Given this list of marker genes ARL4A, MAPK1, TALDO1 (NCBI Gene Id 6888), MED21, FLOT1, COX7A2, MAD2L1BP, NBN, FES, FCER1A, GTF2H5, NAGK, ACSL1, RENBP, CSRNP2, RAI14, ALDOA (NCBI Gene Id 226), RAB31 (RAB31, member RAS oncogene family), HSP90AB1, PROCR, BST1, ABCA3, TUBA1C, SLC27A2, NDUFS6, NTRK1, MS4A6A, MKLN1, PTAFR, TRAPPC4, DAPK2, PMEPA1, QPRT, MARCHF2, BASP1, MEIS2, RHOQ, CCL23, ETNK1 (ethanolamine kinase 1), CYFIP1, RREB1, STK3, NUDT1, PSMC6, DOCK6, DDX41, ETV5, MFAP1, HSD17B4, PINLYP, ENPP2, PAPSS1, IDI1, ZFP69B, EXTL2, MTHFD1, DCTN6 (NCBI Gene Id 10671), MRPL15, IGF2BP3, IL1RN, PLTP, CHST11, TMEM70, PPIP5K2, HS3ST1, CRNKL1, YBX3, LYL1, COPB2, CAVIN2, KLHL2, COA3, PCOLCE, AGPAT4, GPI, EIF4A1, CMA1, TSC22D1, ADGRA3, ENPP4, CHN2, CDC42BPA, COX8A, CHFR, CCT5, VDAC1, WIPI1, DUSP6, DRAM1, NDUFB4, USP48, NQO2, FCER1G, SEL1L, FCGR2C, TMEM53, ACY1, CSF2RB, DST, CERS2, PLXND1, POLR2L, CHST15, TKT, SOX4, LPXN, MSRB2, ARHGEF6, CSNK2B, LYN, NDUFA4, USP22, ZNF804A, EOGT, MT1M, GALC (galactosylceramidase), LYST, ERP44, C1orf216, SQSTM1, MYO1D, ENTREP3, PICALM, UQCRFS1, CHKA, SLC48A1, BLVRA, NPL, ZNHIT1, RASSF2, APMAP, COBLL1, FECH, ATP6V0D1 (ATPase H+ transporting V0 subunit d1), CEBPG, TMSB15B, HEATR6, NDRG2, GSTT1, TCN2, ATP2A2, APC, C5AR1, TIMM8B, TBK1, SOCS5, NME1, GPD1L, COMMD4, FOSL1, ENSA, KCNH2, CKS2, IFNGR1, TXNRD1, PDSS1, ITGAX, PLA2G15, TNPO3, WARS2, SLC30A1, MAFG (MAF bZIP transcription factor G), SPP1, PPM1H, CENPU, WBP4, M6PR, AP4S1, HEXA, MTCH2, GNS, ALDH1A1, WDR12, ILF2, TUBB3, ENY2 (NCBI Gene Id 56943), GSN, NOP16, TPSG1, ACSL4, TMT1A (thiol methyltransferase 1A), SMYD3, CORO1C, TRHDE, TST, PIR, XPNPEP1, HMGCS1, DCAF6, SPRY2, MOB1A, DPY19L1, ABCA1, NDUFS7, MRPL40, CAPRIN1, DUSP10, KATNBL1, ATP5F1B, here is a description of the gene set: In the present study we used Affymetrix oligonucleotide microarrays to produce gene transcription profiles for the major leukocyte types in humans. This comprehensive dataset enabled us to not only establish which genes were expressed in each leukocyte type, but also which genes were expressed in each subset after activation. The used of a comprehensive dataset of gene profiles from all the major human leukocyte subsets enabled a novel and powerful means for identification of genes associated with single leukocyte subsets, or different immune paradigms. Human Gene Set: GSE3982_MAST_CELL_VS_CENT_MEMORY_CD4_TCELL_UP Genes up-regulated in comparison of mast cells versus central memory CD4 T cells. from publication Jeffrey KL, Brummer T, Rolph MS, Liu SM, Callejas NA, Grumont RJ, Gillieron C, Mackay F, Grey S, Camps M, Rommel C, Gerondakis SD, Mackay CR (PMID 16474395) studied in species Homo sapiens